The following is a description of a gene set: species: Mus musculus Mouse Gene Set: CUI_T_CELL_CD8_IL12_RESPONSE_UP Cytokines mediate cell-cell communication in the immune system and represent important therapeutic targets. A myriad of studies have highlighted their central role in immune function, yet we lack a global view of the cellular responses of each immune cell type to each cytokine. To address this gap, the authors created the Immune Dictionary, a compendium of single-cell transcriptomic profiles of more than 17 immune cell types in response to each of 86 cytokines (>1,400 cytokine-cell type combinations) in mouse lymph nodes in vivo. A cytokine-centric view of the dictionary revealed that most cytokines induce highly cell-type-specific responses. For example, the inflammatory cytokine interleukin-1β induces distinct gene programmes in almost every cell type. A cell-type-centric view of the dictionary identified more than 66 cytokine-driven cellular polarization states across immune cell types, including previously uncharacterized states such as an interleukin-18-induced polyfunctional natural killer cell state. from publication Cui A, Huang T, Li S, Ma A, Pérez JL, Sander C, Keskin DB, Wu CJ, Fraenkel E, Hacohen N (PMID 38057668) Genes positively differentially expressed in cell type: CD8+ T cell upon treatment with cytokine: IL-12 in mouse lymph nodes in vivo., and this is the list of marker genes: Nkg7, Stat1, Ncl, Ppp1r14b (protein phosphatase 1, regulatory inhibitor subunit 14B), Eif5a, Pfn1, Gbp7 (NCBI Gene Id 229900), Zbp1, Slc25a5, Gbp2, Psmb10, Ppa1, Irgm1, Hopx, Ran, Iigp1, Irf1, Pim2, Psme2, Icam1, Hspa5, Irf8, Ly6a (lymphocyte antigen 6 family member A), Gbp4, Tap1 (NCBI Gene Id 21354), Ptma, Ifi47, Socs1, Eif2s1, Socs3, Samhd1, Gadd45g, Rtp4, Psmb8, Psmb9, H2-T23, Jaml, Nlrc5, Gbp8, Igtp, Igfbp4 (insulin-like growth factor binding protein 4), Eif4a1, Tagln2